Given this list of marker genes RASSF1, JAK2, NOP10, PSMA5, HINFP, RNPEP, CCNE2, DYNLL1 (dynein light chain LC8-type 1), PRDX4, PPIH, CLPB, BDH1, GPN3, NAT10, METTL8, NDUFA7, FRMD6, TMEM116, STAP2, SLAMF1, POLR2H, TIMM29, SNRPA (NCBI Gene Id 6626), PSMB8, SNX17, CCDC28B (coiled-coil domain containing 28B), SEC23IP, PRCP, TMEM237, WDR12, ANKRD37, SCAMP3, STX4, SLFN11, ZNF788P, TUBB3, HDAC3, ZNF175, GRAP2, MOV10, MRPL43, APPL1, CEP78, SLC25A11, NUDT6, RBBP8, DNAAF10, NSF, DPAGT1, LINC01128, CRTAP, CHMP5, TEDC1, TMUB1, WIPI1, EBI3 (Epstein-Barr virus induced 3), GALK2, APAF1, CORO1B, MICA, NPC1, MCEE, MAP3K21, SF3B3, MRPL37, TFB1M (NCBI Gene Id 51106), MTX2, GMNN, PIGV, SASH3, MCM7, DTD1, IPO5, RFC5, KHK, PIGX, TMEM126B, SDHD, FHOD1, SIVA1, CERS2, ZNF672, LIN9, SERPING1, MKNK2, CD58, NME6, TUBA3D, RAN, CAPZA1, GPX7, NUP37, COA6, GPR157, LMNB2, CGAS, MAGOHB, GLO1, ATP23, LRPPRC, CCNA2, IGIP, CCDC34, PSMC3IP, PPP1CC, RECQL4, UHRF1, C8orf88, MRPL52, INVS, TMEM273, FBXO22, PHF19, ING2, NDUFAF1, FADS1, KRT10-AS1, MRPL17, MAD2L2, ORC6, SPRED2, PKM, CDC25A, BLVRA, TRIB3, CLPP, CKS2, BCAT1, TMEM263, PLP2, DCTN2, RHOF, SLCO4A1, NIPSNAP1, PDHA1, CISD1, UNG, HNRNPLL, LEPR, PREB (prolactin regulatory element binding), GLRX3, MOB3A, CENPI, BUB3 (NCBI Gene Id 9184), C12orf76, SNRPD3, MCMBP, BEND5, CAPG, NEK2-DT, POLE2, CYB5R3, CEP72, CPSF3, MZB1, VBP1, ATP5MC3, MRPL23, ELP5, PRKAG1, SAPCD1, SHMT1, LRP11, GSEC, SLC35A5 (NCBI Gene Id 55032), STARD3NL, FAF1, PAXIP1, KDM7A-DT, COTL1, APOL2, UNC45A, CSNK2B, MDH1, GUK1, ARL6IP6, ZNF691, ACAP1, ATP5F1B, KIF2A, DLEU1, C1QBP, PGRMC1 (progesterone receptor membrane component 1), IDH2, TIFA, GK, PPIL3, SHMT2, LRRC42 (leucine rich repeat containing 42), PEX3, ANKRD6, MSH6, SORD, ALG10, CD226, MLH1, GBP2, RPL23AP7, RAB24, here is a description of the gene set: from publication Elo LL, Järvenpää H, Tuomela S, Raghav S, Ahlfors H, Laurila K, Gupta B, Lund RJ, Tahvanainen J, Hawkins RD, Oresic M, Lähdesmäki H, Rasool O, Rao KV, Aittokallio T, Lahesmaa R (PMID 20620947) Human Gene Set: GSE17974_0.5H_VS_72H_UNTREATED_IN_VITRO_CD4_TCELL_DN The aim of this dataset was to study in detail the transcription kinetics initiated by cytokine IL-4 in early differentiation of Th2 cells. species: Homo sapiens Genes down-regulated in comparison of untreated CD4 T cells at 0.5 h versus the untreated cells at 72 h.